The following is a description of a gene set: Human Gene Set: GOBP_EMBRYO_DEVELOPMENT The process whose specific outcome is the progression of an embryo from its formation until the end of its embryonic life stage. The end of the embryonic stage is organism-specific. For example, for mammals, the process would begin with zygote formation and end with birth. For insects, the process would begin at zygote formation and end with larval hatching. For plant zygotic embryos, this would be from zygote formation to the end of seed dormancy. For plant vegetative embryos, this would be from the initial determination of the cell or group of cells to form an embryo until the point when the embryo becomes independent of the parent plant. species: Homo sapiens, and this is the list of marker genes: OSR2, TADA3, NLRP5, IFT122, RDH10, NECAB1, PKD2, PRPF19, MYCN, MYO18B, TULP3, CCDC39, LHFPL5, FOXF1, UNK, MYO7A, PDZD7, KDM6B, MIR200C, PLCB1, HAND1, ENDOG, SETD2, IGF1, CDC40, ESRRB, MBD3, RRP7A, HSBP1, DSC3, RBM14, ACTR5, DNAJB6, VASH1, YTHDC1, BTF3, BCL10, PHF6 (PHD finger protein 6), TCTN1 (NCBI Gene Id 79600), CDC73, WNT8A, TCOF1, SIX3, CIMAP3, DLX6, TBX5, MFNG, INO80, ZMIZ1, SENP2 (NCBI Gene Id 59343), HOXD12, FOXB1, LFNG, CLRN2, RPGRIP1L, SKI, NEK2, GLI2, DLX3, TTBK2, GLI3, PDGFB, RARA, TLE6 (TLE family member 6, subcortical maternal complex member), DLD, IL10, ALDH1A2, MIR150, PTK7, HOXB3, BAX, TSC1, PBX1, MATR3, GRXCR1, GLI1, COL11A1, NCKAP1, FZD3, FBN1, GRHL3, ZNF335, STOX2, IRX1, RIPPLY1, TSHZ1, GREB1L (NCBI Gene Id 80000), ZEB1, CLUAP1, TBX15, HIF1A, MIB1, TFAP2A (transcription factor AP-2 alpha), CHD8, SEMA3C, HDAC1, CTCF (CCCTC-binding factor), RAC1, NR0B1, VAX2, MYBPHL, EPB41L5, RUVBL1, NR2F2, TIFAB, HSF1, MXI1, CNOT3, GRHL2, VTN, WDPCP (NCBI Gene Id 51057), PALS1, HOXD13, POU5F1, SOBP, SOX15, WNT3A, EN2, MTHFD1L, SUPT20H, MACROH2A1, FZD7, MDFI, SLC25A34, UPF3A, COL8A1, SIX2 (SIX homeobox 2), CCN1, BPTF, TH, TBC1D32, RUNDC1, DKK1, WNT7B, MESP1, CDX1, RNF207, NUP133, ATF4, SF3B6, SP3, CEBPA, E2F8, CCDC62, PRICKLE1, MTHFD1, DMRT2 (doublesex and mab-3 related transcription factor 2), ADGRF5 (NCBI Gene Id 23282), NOTCH1, MFRP, ITGA8, RAI2, PDX1 (NCBI Gene Id 3651), GABPA, MIR1-1, TFEB, RNF112, AMBRA1, PAX6, DLX2, CELF1, ST8SIA6, MYO3B, TENM4 (NCBI Gene Id 26011), CDK1, RALA, WDR74, NOS3, MED1, TBX6, HNF1B, HOXB9, SIN3A, MAF, OTOP1, PEMT, GRN, SYF2, SSR2, FOXG1, PHACTR4, POFUT1, ZBED6, EIF4A3, ETS2, TRIM15, PSPH (NCBI Gene Id 5723), PCSK5 (NCBI Gene Id 96284), HES1, EFNA1, WNT5A, BYSL, INO80C, KIT (NCBI Gene Id 5086), MYH3 (NCBI Gene Id 4621), CDC42, IFT52, RBBP6, GJB5, FZD2, C2CD3, TPO, TPRA1, MAFG, WNT2, CREBBP, HOXA11, NODAL, RAD23B, OTX1, COL1A1, KPNA7, TADA2A, TBX4, PAX8, TRIP12, SCT, MED21, ACVR1C, TASOR, TBX3, UPB1, RARB, VPS52, SCRIB, CDKN1C, PLXNA4, FGF10, TIE1 (NCBI Gene Id 7075), MIR145, EXT1, BBS5, RBP4, COL7A1, CCDC103, TUBB2B, TGFB3, EOMES, WT1, EHMT1, LRP4, DZIP1L, JAG2, STOX1, C1orf43, UCHL5, KCNQ1, FOXI1 (forkhead box I1), WNT9A, HNF4A, ASB2, CLRN1, MAPK7, SMO, REST, ALKBH1, TBXT, ZP3, OFD1, INO80B, TGIF1, GPC3, EIF2S2, RARG, RAD51B, SPIC, CENPU, TPRN, ZBED3, KBTBD8, PAX5, HCFC1, NASP, SOX2, DUSP4, NKD1, FOXI3, LPAR6, ADAM10, CAMSAP3, AFF3, PFN1, COL3A1, IHH, USP22, CMTM3, IL1RN, SEBOX, MBNL1, FBN2, TEAD1, SOX8, OTUD7B, NCAPG2, HMX2 (H6 family homeobox 2), SIX1, RIPPLY2, CXCL8, INSIG1, VEGFA, CHD7, SEPTIN7, SLITRK6, UTP25 (NCBI Gene Id 80064), ITGA3, INPP5B, SETDB2, FBXW4, MYADM (myeloid associated differentiation marker), ZFAND5, CBY1, RPL38, MSX2, WDR5, MAP3K20, TDRD5, FLT3LG, DSCAML1, ZFPM1, MAP2K5, MOSMO, SCX, ZBTB17, MIXL1, RICTOR, CCDC134, RGMA, THOC5, KAT5, FRAS1, TCF15, TAB1, RBM19, KLHL12, WDR19, ARNT2, C2orf49, HUS1 (HUS1 checkpoint clamp component), FLVCR1, RXRB (NCBI Gene Id 6257), WNT1, HOXA7, KRT8, HOXD9, VANGL2, ANKRD24, FN1, YEATS2, RECK, RRN3, HOXA2, TBX2, PSMC3, NUP50, RTF1, EPHA2, YY1, WNT2B, DBN1, MYH9, ATOH8, EN1, MUSTN1, PRKDC, PNLDC1, FZD5, TAL1, CEBPB, PDGFA, TRIOBP, EDN1, PTPRR, PLXNB2, TBX18, ARFRP1, IFITM5, BBS7, ST14, STRA6, LMO4, NLE1, MKKS, TM4SF1, ITGA4, CCNB1, TDRD1, PTPN18, CHRDL1, HESX1, ADM, SMG9, ZFPM2, RPS7, IFT57, EYA1 (NCBI Gene Id 2138), KDM2B, COL2A1, GNA13, HYAL1, SFRP1, TTLL4, NDST1, HOXC5, MAPK1, HIPK1, MED12, ATP6AP2, FOXL2, BCOR, MEIS2, MSX1, DIAPH3, ITGA7, CECR2, GPI, IRX3, JAG1, TGFB2, SPECC1, VASP, MTHFR, HOXA6, GINS1, EPHB2, HOXD8, SOX7, YBX3, INTU, SGF29, ANGPT1, SLC5A7 (solute carrier family 5 member 7), FKRP, KIF20B, SDC4, FLRT3, EFNB1, GBX2, ZFP36L1 (NCBI Gene Id 677), BIRC6, INSR, TTPA, NKX6-3, HES7, SEC24D, APOB, PBX3, KDF1, ZFP14, SOD1, PRRX1, DHX36, MICAL2, TAF8, PAFAH1B1, DACT1, SP8, TCF21, NDUFA2 (NCBI Gene Id 4695), RCN1, HIPK2, TWIST1, SOX10 (NCBI Gene Id 8223), CHST11, ITGB4, NECTIN1, TLX2, CUL4A, FOXN4, PELO, CSF2, STK3, B9D1, CERT1, ACSL4, GATA6, STRC, B4GALT5, GJA5, BAP1, RSPO3, EXT2, MAN2A1, EFEMP1, FOXD3, XRCC2, PITX2, COL5A2, HOXA3, FGF2, MEGF8, PCSK6, FBXW8, TBX20 (NCBI Gene Id 57057), HS6ST1, CHRNA9, SLC39A3, POU3F4, AXIN2, SPECC1L, BCL2L11, TDG, EXOC4 (exocyst complex component 4), CHRD, PRDM14 (NCBI Gene Id 63978), LAMA2, TAPT1, SOX17, CHEK1, ALX3, CELSR1, GDF3, ITGB5, LIF, HMX3, ACTR8, NF2, DLL4, APLNR, TXNRD1, HES5, ROCK2, RAB14, POLR1B (RNA polymerase I subunit B), DEAF1, NKX3-2, GINS4, TDRD7, GDF1, DLL3, RBPMS2, CEP290, NANOG, AGBL4, TMEM231, ETNK2, NSRP1, TET1, ARMC5, MEOX2, ATOH1, HOXC10, LOXL3 (lysyl oxidase like 3), RNASEH2B, POLG2, SLC25A20, INSIG2 (NCBI Gene Id 51141), DISP1, FOXC1, ERCC2, ASF1B, SEMA3F, IGF2, FREM2, POU4F3, SHH, HSD17B2, LIG4, FLT1, SH2B3, TP53, ADA, POLB, PBX2, CCNB1IP1, RBM46, LATS1, HDAC3, PCGF2, FGF4, FGF8, MYF6, CYP26B1, KDM8, RRM2, MEIS1, HOXA10, MAFF, LAMA4, LRP6, CTNNB1, MBIP, CRABP2, CC2D2A, KAT2A, WDR48, NAGLU, COL12A1, SPINT1, CCM2, NECTIN3, CPT2, ALX1, SLC30A1 (NCBI Gene Id 7779), TBX1, ADAMTS3, NBN, CDH23 (cadherin related 23), ZZZ3, MYC, RPS6KA6, HOXB4, EPN1, ALX4, ISL1, MBTD1, NFE2L2, BBS4, ITPK1, TEAD2, MMP2, GRB2, AXIN1, RYR2, CRIPTO, HOXA5, BCR, MMP15, AR, DYNC2H1, NF1, RUVBL2, PAX7, CTR9, SOX9, SOX11, ID3, RPA1, GGNBP2, BRD2, ITGA2, PLPP3, TECTA, HOXB1, CCDC24, BMPR1A, PLK4, SEMA4C, NOTCH2, NOLC1, HTR2B, ZNF830, MBD2, MYH6, DUSP1, BPNT2, BRK1, SMAD1, DLX5, FXN, KIFBP, INPP5K, KIF16B, TOP1, MMP16, APBA1, LEF1, FOXH1, ACVRL1, CACNA1C, SALL1, PRDM1, PIK3CB, AHI1, IL3, TGFB1, TMIE, NPM2, PRKRA, ENSG00000285205, GREM2, SUFU, KDR, PLS1, SIX4, RIPPLY3, FUZ, DLX1, HS2ST1, MYB, NR2C2, PCDH12, GDNF, XAB2, OTX2, HLX, TFAP2C, PDGFRA, HAND2, APAF1, YAP1, EMG1, WNK1 (NCBI Gene Id 9872), ARHGDIG, CRYAA, NAT8B, HDAC2, TBC1D23, ERCC3, MT-ND4, NPHP3, SLC34A2, DNAAF2, FGFR2, ITGAV, HEG1, EDNRA, ADIPOQ, YBX1, BNIP2, COPS2, DCHS1, NPAT, CITED1, DHX35, PSEN1, PADI6, ATM, COL5A1 (NCBI Gene Id 1289), DAD1 (defender against cell death 1), HORMAD1, ROCK1, POLE, ZBTB16, VPS54, APBA3, ETV2, KITLG, FBLL1, TRAF3IP1, PLPP4, NES, GRSF1, FLCN, BASP1, LEO1, CHRNA10, NXN, PRKAR1A, SOCS3, HOXA13, KMT2A, TOP2A, ARL13B, CMIP, UBE2B, WNT4, HEY1, INO80E, DR1, AKT1, NRP1, PLD6, HINFP, APLN, APOA1, E2F7, MAFB, HOXC11, SHOX2, POGLUT1, LAMB3, KCNQ4 (potassium voltage-gated channel subfamily Q member 4), OSR1, KAT14, SMARCB1, ACD, CNOT2, HSD17B7, NCOA1 (NCBI Gene Id 8648), PITX1, HOXA4, DYNC2I1, IFT140, MYH10, PEF1 (NCBI Gene Id 553115), CDK20, RACGAP1, SFRP2 (NCBI Gene Id 6423), WDTC1, TGFB1I1, HOXC4, SEC24C, LUZP1, FUT8, OVOL2, TGIF2, PBX4, GJB6, RTCB, KLF4, PLG, KIAA1217, TNF (NCBI Gene Id 7124), NR4A3, PRMT1, ZNF358, BMI1, TDRKH, NDEL1, N4BP2L2, SLC2A10, GATA4, ITGB1, MKS1, SLC35E2B, DLX4, GPR161, MMP14, PHLDA2, PAX2, MIR221, SOS1, MYO1E, TRIM28, DUSP2, PHGDH, SUV39H1, SLC35D1, C6, APBA2, SATB2, LAMA5, SMAD2, EGFL8 (NCBI Gene Id 80864), DLC1, LAMA1, JUNB, THOC2, MCRS1, BMP2, STK4, BCL2L1 (NCBI Gene Id 598), IRX5, SKIL (NCBI Gene Id 6498), EGLN1, MYF5, LLGL2 (NCBI Gene Id 3993), HOXD4, INHBA, BRD3, SLC39A1, TTC39C, NDRG4, EMP2, CNOT1, TDRD6, NKX2-5, MFN2, FOXE1, NSUN2, HOXD1, ZIC1, COL4A2, GSE1, NFRKB, TFPT, IWS1, MAPK3, CCNB2, APELA, INTS1 (NCBI Gene Id 392616), TMED2, NEUROG1, CDX2, LRIG3, ZIC3, EPAS1, SCO2, PGAP1, TMEM100, BMP7, LBX1, GDF5, GRXCR2, FOXA1 (NCBI Gene Id 3169), WNT7A, ARNT, EMX1, GATA2, IRX2, SPINT2, PAX1, HIRA, CHTOP (NCBI Gene Id 91678), AKIRIN2, GREM1, WNT8B, COL6A1, TGFBR1, CCDC40, NRP2, PRKACB, PTH1R, ZNF281, PALB2, KHDC3L, HOPX, FURIN, LAMA3, LAMB1 (laminin subunit beta 1), HSCB, LRP5, ARID2, SULF1, FOXA2, CDX4, LIAS, GCM1, NOCT, PPP1R35, RET, RPL10, PPP1R13L, KLF2, ZPR1, TP63, LHX1, WNT11, ID2, RARRES2, COBL, LRP2, SLC39A12, ERBB4, NSDHL, RTN4, BAG6, HM13, ALDH1A3, TRA2B, MAP2K1, KDM4C, LRIG1, RPL7L1, HOXD3, SALL4, TEAD3, ZNF568, RACK1, LDB1, PRKACA, CXXC4, FOXC2, SNAI1, UBTFL1, ITGB3, RBBP8, RBPJ, UCMA, ATF2, YTHDF2, PKD1, OOEP, WDR83, FKBP8, VASH2, HOXB5, SOX18, HPN, STMN3, PPIL1, AKAP3, LATS2, TSC2, NOTO, CCSAP, ACTL6A, EYA2, ACVR2B, EP300, ITGA5, ACVR2A, MSH2, SCEL, CFL1, EGFR (NCBI Gene Id 1956), NTN1, FGF9, E4F1, RUNX2, SSBP3, TTLL1, KAT2B, ABI1, RIC8A, SPARC, BMP5, PDCD6, ASCL2, RNF2, WNT5B, KRT19, EVX1, NHERF1, FRZB, HOXD10, BMP4, SMAD4, ATP8A2, WNT3, BMPR2, LNPK, LMBRD1, MYO6, RPL13, HOXB8 (homeobox B8), PTCH1, ABL1, NMT1, TGFBR2, MYO3A, LBX2, SIM2, USH1G (USH1 protein network component sans), USH1C, PPP2R3A, DLL1, TAF10, OPA1, MEIS3, HOXC6 (homeobox C6), CELF4, HOXA1, PAF1, FKBP10, FZD6, MESP2, CDON, SPRY2, PKDCC, TRAF6, TENT5C, ELF3, GLMN, SP9, XYLT1, FERD3L, TBX19, SRSF1, TBL1XR1, PPP1CC, HMGA2, PCDH8, OCRL (OCRL inositol polyphosphate-5-phosphatase), RNF220, MFAP5, FGFR1, ACVR1B, PCDHA10, HOXB7, ADCY9, ECE1, WLS, SMIM14, GDF7, SMAD3, CER1, HOXA9, CRB2, SMAD5, HOXC9, ZEB2, INO80D, SULF2, MAB21L2, TWSG1, NIPBL, PLCD3, MFSD2A, RSPO2, POFUT2, HOXB2, STIL, MEOX1, SRF, HS3ST6, MARCKS, CUL3, LMBR1, WNT6 (Wnt family member 6), WNT16, TERF2, AHDC1, NOG, ENG, NKX2-6, DVL2, BRCA2, SLC44A4, CIR1, NEUROD1, GSC, GATA3, MBP, TMEM107, DLG1, LHX2, IFT172 (NCBI Gene Id 26160), TRIP6, PLOD3, MSGN1, GATA1, PSMC4, CITED2 (Cbp/p300 interacting transactivator with Glu/Asp rich carboxy-terminal domain 2), HOXD11, NKX3-1, DCANP1, AMOT, BRCA1, WNT9B, DNAAF1, COPS3, GJA1, SEC24B, CDKN1A, NRARP, HEY2, PLXNA2, BLOC1S5, CAPN2, CFC1B, FOXF2, MMP8, FRS2, UGDH, CASP8, KEAP1, HOXB6, DUSP5, CFC1, DVL1, TEAD4, TRIM71, GNA12, PROX1 (prospero homeobox 1), MGAT1, VEGFC, CTHRC1, SMAD6, ANKS6, MEIS3P1, ARHGAP35, ELL, ITGB2, MFAP2, ATP6V1B1, SH3PXD2A, ACVR1, FOSL1, PPP4R4, MMP9, UBR3, TCAP, FOLR1, DOP1B, KIDINS220, AATF, CASP3, WHRN, NR5A2, MEF2C, ELF5, SUPT6H, MYO15A, SBDS